The following is a description of a gene set: Catalysis of the hydrolysis of a dipeptide. Human Gene Set: GOMF_DIPEPTIDASE_ACTIVITY studied in species Homo sapiens, and this is the list of marker genes: ADAM10, DPEP2, CPQ, ADAM17, PEPD, FOLH1B, DPEP3, SCRN2, MEP1A, NAALAD2, PM20D2, SCRN3, CNDP2, CNDP1, SCRN1, ACE, FOLH1, DPEP1